The following is a description of a gene set: Mouse Gene Set: REACTOME_SYNTHESIS_OF_IP3_AND_IP4_IN_THE_CYTOSOL studied in species Mus musculus Synthesis of IP3 and IP4 in the cytosol, and this is the list of marker genes: Plcz1, Itpka, Pld4, Plch1, Pten, Itpkb, Plcg2, Plch2, Plcd1, Ocrl, Plce1, Calm1, Plcb3, Plcg1, Inpp5d, Plcd4, Inpp5b, Calm3, Plcb1 (phospholipase C, beta 1), Calm2, Synj1, Plcb2, Plcb4, Inpp5j, Itpkc, Itpk1, Plcd3, Inppl1